Given this list of marker genes AFG1L, YME1L1, BNIP3, PRKACA, PISD, CLPP, LONP1, BNIP3L, HTRA2, SPATA18, here is a description of the gene set: species: Homo sapiens The chemical reactions and pathways resulting in the breakdown of a mitochondrial protein. This process is necessary to maintain the healthy state of mitochondria and is thought to occur via the induction of an intramitochondrial lysosome-like organelle that acts to eliminate the damaged oxidised mitochondrial proteins without destroying the mitochondrial structure. Human Gene Set: GOBP_MITOCHONDRIAL_PROTEIN_CATABOLIC_PROCESS